Given this list of marker genes KDELR1, MME, FAS, CCDC85B, MPP3, NFKB2 (nuclear factor kappa B subunit 2), PRPF18, XIST, GPR31, VGLL4, PRIM2, PNMT, here is a description of the gene set: from publication Högerkorp CM, Bilke S, Breslin T, Ingvarsson S, Borrebaeck CA (PMID 12411303) Human Gene Set: HOEGERKORP_CD44_TARGETS_TEMPORAL_UP Genes temporally up-regulated by CD44 stimulation of B lymphocytes. A number of studies have implicated a role for the cell surface glycoprotein CD44 in several biologic events, such as lymphopoiesis, homing, lymphocyte activation, and apoptosis. We have earlier reported that signaling via CD44 on naive B cells in addition to B-cell receptor (BCR) and CD40 engagement generated a germinal center-like phenotype. To further characterize the global role of CD44 in B differentiation, we examined the expression profile of human B cells cultured in vitro in the presence or absence of CD44 ligation, together with anti-immunoglobulin (anti-Ig) and anti-CD40 antibodies. The data sets derived from DNA microarrays were analyzed using a novel statistical analysis scheme created to retrieve the most likely expression pattern of CD44 ligation. Our results show that genes such as interleukin-6 (IL-6), IL-1alpha, and beta(2)-adrenergic receptor (beta(2)-AR) were specifically up-regulated by CD44 ligation, suggesting a novel role for CD44 in immunoregulation and inflammation. studied in species Homo sapiens